Given this list of marker genes Ppp2r5b, Foxo4, H2-M3, Dab2ip, Znhit1, here is a description of the gene set: A cell cycle process that stops, prevents, or reduces the rate or extent of the transition from the G0 quiescent state to the G1 phase. species: Mus musculus Mouse Gene Set: GOBP_NEGATIVE_REGULATION_OF_G0_TO_G1_TRANSITION